Given this list of marker genes STAP2, AQP6, HAAO, PGPEP1, CDO1, SNHG17, HOXC11, NCK2, NXT1, TRIM9, CPZ, GPC1, CDH6, ZNF124, FHL3, TTC21B, SFTPD, TOP3B, CRABP1, TNXB, TULP3, SEMA3B, ADRB3, SLCO1C1, COMT, CPS1, S100A5, TSC22D4, FOXE3, HDC, TMED1, SPP1, PES1 (NCBI Gene Id 23481), TFAP2B, MAP3K13, CLEC4M, PYCARD, CALCR, MEF2D, LDB2, FOXC2, ARHGAP44, JAG1, RLIG1 (NCBI Gene Id 91298), NDUFA4L2, ETV3, HOXB8, CBX6, NCAPH2, NLRX1, SENP2, SERPINA6, PIP, CRABP2 (NCBI Gene Id 1382), ELAC2, NSUN6, RBM41, SNPH, IL18BP, MSX2, RPP40, HR, MATN2, WNT2, ROBO1, CRHR2, NAA60, CARTPT (NCBI Gene Id 9607), PTMS, ATAD2B, ETHE1, AOPEP, CHAT, OR7A5, FKTN, ATP1B2, BIRC7, CARM1, SLC25A44, GIPR (gastric inhibitory polypeptide receptor), ZFYVE21, SLC16A8, ISLR, TBXT, CLDN17, CSH2, CLMN, MRC2, SPANXC, SV2A, ZNF446, DAZAP1, SGPL1, LRRC37A3, PTPN14, THNSL2, FPGS, THBS3, ALDOC, HROB, ADAMTSL2 (ADAMTS like 2), PSMG2, C1orf21, CLDN10, TMEM243, APOO, GAS8, CNGA1, BEGAIN, SCGB1D2, SEMA6B, ZMAT3, METTL25B, ARHGEF26, LMNA, OLFML2A, UPF1, CSPG4, CD5L, CYTH1 (cytohesin 1), CFL1, UMPS, SOCS2, TMEM50B, USP3, CCR3, STIL, CD300A, PTK7, PCLO, ADGRB3, ZNF688, SLC24A2, ZNF180, CDC42EP3, CCDC51 (NCBI Gene Id 79714), OPA1, MRPS18C, MTARC1, DEFA6, NAT8B, ELOA, PKD1L1-AS1, NEURL1, PLCL1, YIPF5, TIMP1, PARVA, BTBD2, PRSS1, GALNT8, NDRG2, MRPS18A, MAN1C1, PLCD1 (phospholipase C delta 1), CCNF, OR7C1, NES, DNAJA4, MMP19, PDC, SFN, HSD11B2, IRF6, BAAT, ADISSP, EML1, TCAP, SIPA1, LGR5 (NCBI Gene Id 8549), CPN2, PLAT, PCDH1, THOC6, CCZ1B, WDR46, BSPRY, HAO2, RAB3A, HIGD1B, PEG3, GDAP1L1, FBN1, HAPLN2, LY6G5C, PROX1, TP53TG5, EFNA3, ARHGEF4, MEIS2, VPS26C, PSTPIP1, GCKR, PPP5C (NCBI Gene Id 5536), FASTKD3, B9D2, here is a description of the gene set: Systems vaccinology has emerged as an interdisciplinary field that combines systems wide measurements and network and predictive modeling applied to vaccinology. Here we used the systems vaccinology approach to study the molecular mechanisms underlying th studied in species Homo sapiens from publication Nakaya HI, Wrammert J, Lee EK, Racioppi L, Marie-Kunze S, Haining WN, Means AR, Kasturi SP, Khan N, Li GM, McCausland M, Kanchan V, Kokko KE, Li S, Elbein R, Mehta AK, Aderem A, Subbarao K, Ahmed R, Pulendran B (PMID 21743478) Genes up-regulated in comparison of B cells from influenza vaccinee pre-vaccination versus those at day 7 post-vaccination. Human Gene Set: GSE29618_PRE_VS_DAY7_FLU_VACCINE_BCELL_UP